Given this list of marker genes Fanca, Fancl, Faap20 (Fanconi anemia core complex associated protein 20), Fancb (Fanconi anemia, complementation group B), Fancm, Fancc, Cenpx, Fanci, Cenps, Fancf, Faap24, Fance, Faap100, Fancg, here is a description of the gene set: A protein complex composed of the Fanconi anaemia (FA) proteins including A, C, E, G and F (FANCA-F). Functions in the activation of the downstream protein FANCD2 by monoubiquitylation, and is essential for protection against chromosome breakage. Mouse Gene Set: GOCC_FANCONI_ANAEMIA_NUCLEAR_COMPLEX studied in species Mus musculus